The following is a description of a gene set: An ulcer, that is, an erosion of an area of the gastric mucous membrane. studied in species Homo sapiens Gastric ulcer Human Gene Set: HP_GASTRIC_ULCER, and this is the list of marker genes: ARID1B, WFS1, PLA2G4A, CISD2, STAT3, GBA1 (NCBI Gene Id 82008)